Given this list of marker genes DPH3, EEF2, DPH1, DNAJC24, DPH7 (diphthamide biosynthesis 7), DPH5 (NCBI Gene Id 51611), DPH6 (NCBI Gene Id 89978), DPH2, here is a description of the gene set: part of: Gamma carboxylation, hypusinylation, hydroxylation, and arylsulfatase activation Eukaryotic elongation factor 2 (EEF2) catalyzes the GTP dependent ribosomal translocation step during translation elongation. This function requires the presence of a posttranslational modification, the conversion of histidine residue 715 to diphthamide (2' L histidine) (Van Ness et al. 1978). No other protein is known to undergo this modification. The diphthamide residue is also the target of ADP ribosylation catalyzed by diphtheria toxin, which inactivates EEF2 and leads to cell death.<p>Diphthamide synthesis proceeds in four steps: the transfer of 3 amino 3 carboxypropyl group from S adenosylmethionine to histidine 715 of EEF2, the addition of four methyl groups to the 3 amino 3 carboxypropyl moiety, the demethylation of the methylated carboxylate group to form diphthine, and the amidation of the diphthine carboxyl group. Reactome Pathway: Synthesis of diphthamide-EEF2 studied in species Homo sapiens